The following is a description of a gene set: Human Gene Set: GOBP_REGULATION_OF_SYNAPSE_STRUCTURAL_PLASTICITY Any process that modulates the frequency, rate or extent of synapse structural plasticity. Synapse structural plasticity is a type of cytoskeletal remodeling; this remodeling is induced by stimuli that can lead to long term potentiation and it can be activity-dependent or -independent. Examples of cytoskeletal changes include the formation of new spines and increase in spine size; this can be accompanied by the insertion of greater numbers of glutamate (or other neurotransmitter) receptors into the post-synaptic membrane. species: Homo sapiens, and this is the list of marker genes: DMPK, CTNNA2, CAMK1, FRMPD4, CAMK2B, DRD2, SHANK3